The following is a description of a gene set: Human Gene Set: GSE360_HIGH_DOSE_B_MALAYI_VS_M_TUBERCULOSIS_DC_DN from publication Chaussabel D, Semnani RT, McDowell MA, Sacks D, Sher A, Nutman TB (PMID 12663451) studied in species Homo sapiens Monocyte-derived dendritic cells (DC) and macrophages (MΦ) generated in vitro from the same individual blood donors were exposed to five different pathogens, and gene expression profiles were assessed by microarray analysis. Responses to Mycobacterium tuberculosis and to phylogenetically distinct protozoan (Leishmania major, L. donovani, Toxoplasma gondii) and helminth (Brugia malayi) parasites were examined, each of which produces chronic infections in humans yet vary considerably in the nature of the immune responses they trigger. Genes down-regulated in comparison of dendritic cells (DC) exposed to 50 worms/well B. malayi versus DC exposed to M. tuberculosis, and this is the list of marker genes: SERPING1, ATF5, TSC22D3, TALDO1, CGRRF1, PLXNC1, ACVRL1, OLR1, LDLR, IL2RA, B3GNT2, BCAT1, LRP8, ATP6V1E1, ARPC3, PPP1R15A, VCAM1, CCL4, NDRG1, IQSEC2, GMPR, S100A11, FZR1, CRYBA1, ELL2, HSP90B1, IFIT2, G0S2, ZKSCAN1, PRSS8, WTAP, KRTAP26-1, VCAN, CHST2, S100A8, ZNF410, HSBP1, BTN3A3, CNOT9, CTSL, GNRH2, DLEC1, S100A9, WARS1 (tryptophanyl-tRNA synthetase 1), ACP2, MSC, MMP7, SPTB, TIMP1, MUC6, TRIM38, CYP4B1, TNFAIP2, KCNJ4, PSMD1, OAS2, AMHR2, RCAN1, ARL4A, VRK2, TRIM22, TRAF1, SPINK4, BRCA2, MSMO1 (methylsterol monooxygenase 1), PARP2, IRF6 (interferon regulatory factor 6), KCNV2, TUBB3, CCL7, PSMA3, DUSP1, AASS, AGRN, PLIN2, KCNMA1 (NCBI Gene Id 3778), SBNO2, CSF2RB (NCBI Gene Id 3564), PSME2, PSMB10, MYOF (myoferlin), PLSCR1, EXOC6B, CD163, DENND3, RHOBTB3, SEMA6A, PDPN, CYP1B1, ADAM19, MT1E, MMP9, CD48, TUBB2A, MT1G (metallothionein 1G), CXCL5, ABI1, MX2, UBE2L6, PARK7, IL10RA, RGS1, TP53BP2, SOD3, DYNLL1, THOC2 (NCBI Gene Id 57187), DUSP6, HOXC11, TOMM34, CCL8, CDO1, GLRX, STX11, GPD2, SQLE, BST2, NCDN, F3, ENDOD1, IFI44L (interferon induced protein 44 like), MT1B, ITGB3, STK4, MICB, CYRIA, IFIT1, RAPGEF2, GLUL, NHERF2, LAMTOR5, CDC42, CEP170B, IFI44, NFKBIA, RNF19B, CYBB, TRIM21, MMP12, CST7, GADD45B, AK4, CD83, TXN, VAMP5, ANKRD12, BAZ1A, DNAJA1, MT1F, PLCH1, CA12, PTGER4, ICAM1, LCP1 (NCBI Gene Id 3936), MAP2K3, RTN1, CCL2, DUSP5, UBE2L3, MT3, CRLF3, TLR1, MANF, HIC2, BPI, NREP, CCR7, SLC12A4, CYP2D6, MT1H, GAL, MGLL, GCH1, PSMC1, IFNG, NFKB1, GBP2, ADA, IER3, FCGR3A, SAT1, KAT2B, B4GALT5, PRELP, CDH1, H2BC21, SRSF3, SERPINA1, NR4A3 (nuclear receptor subfamily 4 group A member 3), IFI6, ILF2, GBP1, SYMPK, TYMP, MTF1, MT2A, IL1RN, MORF4L2, DBI, CTAG2, STK17A